Given this list of marker genes ARPC4, WASHC4, ARPC1B, WASHC3 (NCBI Gene Id 51019), GSN, BRK1, AP1AR, FCHSD2, CORO1A, GMFB, ARPIN, LMOD3, SCIN, CARMIL3, ARPC5, LMOD2, ACTR2, CORO1B, ARPC1A, WASF1, ARFIP2, GMFG, WASHC2A, FMN1, WHAMM, MAGEL2, WASHC5 (NCBI Gene Id 9897), LMOD1, CARMIL1, CYFIP1, CTNNA2, DNAI3, ABI2, WIPF3, WASF2, WASF3, ARF1, PICK1 (NCBI Gene Id 9463), ACTR3, CARMIL2, ARPC3, DIAPH3, WASH6P, SPIRE2, ARFIP1, ARPC2, SPIRE1, RNH1, IQGAP2, WASHC1, WASHC2C, NCKAP1, ARPC5L, TRIM27, WASH3P, VIL1, JMY, HIP1R, here is a description of the gene set: Human Gene Set: GOBP_ACTIN_NUCLEATION species: Homo sapiens The initial step in the formation of an actin filament, in which actin monomers combine to form a new filament. Nucleation is slow relative to the subsequent addition of more monomers to extend the filament.